The following is a description of a gene set: Systems vaccinology has emerged as an interdisciplinary field that combines systems wide measurements and network and predictive modeling applied to vaccinology. Here we used the systems vaccinology approach to study the molecular mechanisms underlying th from publication Nakaya HI, Wrammert J, Lee EK, Racioppi L, Marie-Kunze S, Haining WN, Means AR, Kasturi SP, Khan N, Li GM, McCausland M, Kanchan V, Kokko KE, Li S, Elbein R, Mehta AK, Aderem A, Subbarao K, Ahmed R, Pulendran B (PMID 21743478) Human Gene Set: GSE29618_PRE_VS_DAY7_FLU_VACCINE_PDC_UP Genes up-regulated in comparison of plasmacytoid dendritic cells (pDC) from influenza vaccinee pre-vaccination versus those at day 7 post-vaccination. species: Homo sapiens, and this is the list of marker genes: ICOS, SIX5, ZNF428, DHRS2, NAA80, TOP3B, PIR, REPS1, ZIC4, CLCN4, EDA2R (NCBI Gene Id 60401), OR7A17, TDRKH, PRSS22, RAB40A, NHERF2, CILP, ERBB3, SYNJ2BP, PCSK5, PTPN3, IMPG1 (NCBI Gene Id 6673), ADRA1B, WSCD2, ZFP2, SETD5, SLC2A2, TRIM49, ROBO4, LARP6, NCLN, OR2F2, TUBG1, PLS1, MAP3K9, IFI6, ALAS2, NRAP, TGM5, BPNT1, TM9SF1, IL36G, TPRA1, NKX2-2, WDR55, ST20, MSRB2, PALM, HMGN5, IGFBP5, OR2B6, WWC3, RNF126P1, CDA, GFOD2, METRN (NCBI Gene Id 79006), TM4SF1, TFCP2L1, WT1, ARMC9, MEP1A, YBX2, METTL2B, FOXN1, ETV1, KCTD15, JCAD, KLK1, B3GNTL1, KPLCE, NEUROG2, SERPINC1, LRPAP1, DSG1, DIRAS2, SLCO1B1, CKB, HOXB7, CRISPLD2, PRELID3A, PEX12, CHAT, OR7C2, OBSCN, KIF2C, KCNJ16, SYT5 (NCBI Gene Id 6861), IGFBP1, TELO2, NAT8, ACVR2B, GPR135, SLC8A2, MADD, HTR1D, KHK, ZNF512B, DHX8, SCN2B, TMSB15A (NCBI Gene Id 11013), BFSP2, ATG16L1, TXNRD3, SOX10, PTPRR (protein tyrosine phosphatase receptor type R), EFEMP1, ZKSCAN5, CCL25, GRB10, LGALS14, TNNC2, RGS4, IL17B, NRXN2, STON1, GRIN2B (NCBI Gene Id 2904), INTS15, SFRP1, KLK2, ACY1, SLC5A12, SMG6, ATXN7L1, PTGDR2, ACTN3, GIMAP6 (NCBI Gene Id 79765), PPDPF, CLIC5, MYH15, H2AC15, ASIC3, DUS2, OR2C1, ARAP3, CDC42EP1, ITPKC, LPA, GDF10, DNASE2B, RIPK4, COPG2IT1, LEF1, PTPRD, LGR5, LHX1, MYBPC2, CEND1 (cell cycle exit and neuronal differentiation 1), MID2, VWA7, STC2, CRYGD, ISL1, OGN, LPCAT4, BRINP3, SCN2A, HCG9, TMEM158, PRDM14, NDRG4, PHLDB1, KPTN, SIK2 (NCBI Gene Id 23235), SPOCK3, SH3GL3 (SH3 domain containing GRB2 like 3, endophilin A3), KCNIP2, UBXN6, SERPINE1, ODAM, DRD2, KRTAP2-4, ZFYVE21, PSORS1C1, SPATA31C2, CACFD1, TACR1, FOXF1, APOM, TUBB1, SLC26A6, C8B, RNF126, IGSF3, AQP1, EPB41L4B (erythrocyte membrane protein band 4.1 like 4B), NAV2, TLR3, L1CAM (L1 cell adhesion molecule), TF, SEZ6L2, KCTD14, ABCB8, MYH13, SEC14L1P1 (NCBI Gene Id 732095), ADAMTS8, GPR137, MAPK12, FAM182A, CPN1